The following is a description of a gene set: Human Gene Set: REACTOME_SYNTHESIS_OF_16_20_HYDROXYEICOSATETRAENOIC_ACIDS_HETE Synthesis of (16-20)-hydroxyeicosatetraenoic acids (HETE) studied in species Homo sapiens, and this is the list of marker genes: CYP2C8, CYP1A1, CYP2U1, CYP4A11, CYP2C9, CYP1A2, CYP1B1, CYP2C19, CYP4F2